Given this list of marker genes NCF1, DNAJC30, GTF2IRD2, GTF2IRD1, TBL2, METTL27, BAZ1B, BUD23, GTF2I, CLIP2, RFC2, INSR, EIF4H, STX1A, TMEM270, ELN, VPS37D (NCBI Gene Id 171020), ITPR1, LIMK1, FKBP6, FARSA, HEPHL1, here is a description of the gene set: species: Homo sapiens Human Gene Set: HP_ELFIN_FACIES This is a description previously used to describe a facial form characterized by a short, upturned nose, wide mouth, widely spaced eyes, and full cheeks. Because of the imprecision in this definition it is preferable to describe these features precisely. This term is retained because it was often used in the past, but it should not be used for new annotations. Elfin facies